Given this list of marker genes Bdh2, Elane, Bloc1s6, Gclc, Pcsk1, Slc1a1, Nod2, Eif2ak3, Ggt1, Furin, Pcsk5, Lgals4, Gclm, Aasdh, Nfe2l2, Slc1a2, Ggt6, Dmd, Mgst2, Hagh, Slc7a11, Klk1b1, Ggt7, Ggt5, Gss, Mmp7, Cryaa, here is a description of the gene set: species: Mus musculus The chemical reactions and pathways resulting in the formation of peptides, compounds of 2 or more (but usually less than 100) amino acids where the alpha carboxyl group of one is bound to the alpha amino group of another. This may include the translation of a precursor protein and its subsequent processing into a functional peptide. Mouse Gene Set: GOBP_PEPTIDE_BIOSYNTHETIC_PROCESS